The following is a description of a gene set: studied in species Homo sapiens Human Gene Set: HP_GALACTOSURIA Galactosuria Elevated concentration of galactose in the urine., and this is the list of marker genes: FOXP2, GALT, GALE, GALK1, SKIC3